The following is a description of a gene set: species: Mus musculus Any process that modulates the frequency, rate or extent of the PERK-mediated unfolded protein response. Mouse Gene Set: GOBP_REGULATION_OF_PERK_MEDIATED_UNFOLDED_PROTEIN_RESPONSE, and this is the list of marker genes: Ddrgk1, Akt3, Abca7, Akt2, Ptpn2, Nck1, Nck2, Tmem33, Ptpn1, Bok, Igtp, Atad3a, Akt1, Agr2, Hspa5